Given this list of marker genes POGLUT1, ALG5, PLOD3, EPM2A, ALG10, GBA1 (glucosylceramidase beta 1), UGGT1, GYG1, POGLUT3, GYG2, ALG6, GBA2, GYS1, PLOD2, UGGT2, ALG8, UGCG, ALG10B, POGLUT2, PLOD1, GYS2, here is a description of the gene set: Catalysis of the transfer of a glucosyl group to an acceptor molecule, typically another carbohydrate or a lipid. Human Gene Set: GOMF_GLUCOSYLTRANSFERASE_ACTIVITY species: Homo sapiens